Given this list of marker genes PLXNA1 (NCBI Gene Id 84202), DPYSL4, CDK5R1, CDK5, CRMP1, GSK3B, NRP1, PLXNA3, PLXNA2, SEMA3A, DPYSL3, PLXNA4, FES, DPYSL2, DPYSL5, FYN, here is a description of the gene set: Reactome Pathway: CRMPs in Sema3A signaling species: Homo sapiens part of: Semaphorin interactions CRMPs are a small family of plexinA-interacting cytosolic phosphoproteins identified as mediators of Sema3A signaling and neuronal differentiation. After Sema3A activation Plexin-A bound CRMP's undergo phosphorylation by Cdk5, GSK3beta and Fes kinases. Phosphorylation of CRMPs by these kinases blocks the ability of CRMP to bind to tubulin dimers, subsequently induces depolymerization of F-actin, and ultimately leads to growth cone collapse.